Given this list of marker genes Ampd2, Nme6, Gnai3, Nme1, Ak4, Efl1, Nme2, Lrrk2, Gtpbp1 (GTP binding protein 1), Impdh1, Nme7, Opa1, Entpd7, Gimap7, Rhoa, Impdh2, Nme3, Ampd3 (NCBI Gene Id 11717), Nme4, Rhoq, Mfn1, Ran, Pnp, Nme5, Ak3, Rab23, Impdh2-ps, here is a description of the gene set: The chemical reactions and pathways involving GTP, guanosine triphosphate. species: Mus musculus Mouse Gene Set: GOBP_GTP_METABOLIC_PROCESS